The following is a description of a gene set: Abnormal upper limb metaphysis morphology An anomaly of one or more metaphyses of the arms. species: Homo sapiens Human Gene Set: HP_ABNORMAL_UPPER_LIMB_METAPHYSIS_MORPHOLOGY, and this is the list of marker genes: COL10A1, NDN, GNAS, TRAPPC2, EZH2, RECQL4, TRPV4, SNRPN, STX16, ANAPC1, MAGEL2, COL2A1, COMP, RPL13 (NCBI Gene Id 6137), GNPNAT1, MMP13, PHEX, MMP9